The following is a description of a gene set: Genes predicted to be targets of miRBase v22 microRNA hsa-miR-597-3p in miRDB v6.0 with MirTarget v4 prediction scores > 80 (high confidence targets). Human Gene Set: MIR597_3P studied in species Homo sapiens from publication Chen Y, Wang X (PMID 31504780), and this is the list of marker genes: BOLL, SYN1, GTF2B, SPN, COQ4, IL2RA, CLVS1, YWHAE, SGSM1, CXADR, USP18, RIC3, PPTC7, SLC46A3, PRDM11, LDAH, BCL2L1, FYCO1, PIK3C2A, KCTD15, PREPL, TSPAN11, FAM221B, DIXDC1, SOCS2, C4orf3, BTBD7, CAB39L, CBX1, TSHZ3, CTDSPL, CADM1, SDC1 (syndecan 1), TDRD1, LRTOMT, SEMA5A (semaphorin 5A), SEMA3D, KYAT1, SMIM12, ARL4C, CNN3, RALGPS1 (NCBI Gene Id 9649), CGN, SPATA33, MAP1LC3B, RAB6B, UBN1, MDH1B, EIF4H, RBMS1, CDK2, LPAR5, IGLON5, FRMD6, TOR1AIP2, PYGO2, SEMA6D, FCRLA, PHACTR2, FAM168A, PTDSS2, TIGIT, RBMS3 (NCBI Gene Id 27303), DACH1, GRM5, CAPRIN1, PHACTR1, C22orf46P, HMGXB4, SDK1, KLF11, ATG14, HECTD2, HECA, SYNJ2BP, ALG6, KRTAP9-2, LAMP2, KLHL42, SGPL1, FBXO28, SNX25, UNC5D, PAK5, KRTAP9-8, EHF, NRAS, NAP1L1, GPATCH2L, BNIP2, LDLRAP1, RHBDL3, GLIS3, GXYLT1, DPH2, E4F1, MYH9, PTPRQ, APOL2 (apolipoprotein L2), BIRC6, ONECUT2, LTBP2, CXXC5, ARID5B, IYD, RFX3, DNAJB1